Given this list of marker genes MACF1, ITGA4, CITED2, SKAP1, CD28, MUC1, SOCS6, CDH13, WASHC2C, HLA-DQA1, ACTG1, NF2, EBI3, IFNL1, PDPK1, RSU1, GNRH1, SNAI2, EMP2, BTNL2, CYTH1, CARMIL1, UBASH3B, ADAMDEC1, ILDR2, CARD11, CD37, KANK1 (NCBI Gene Id 23189), PLAU, HSPD1, CYLD, NR4A3, NDFIP1, NRP1, PIK3CD, MIR146A, SMARCC1, PRKG1, FSTL3, LRFN3, CTNNB1, MIR138-1, MIR125A, ERBB3 (NCBI Gene Id 619500), ARG2, F11R, FLOT2, MIR92A1, PLXNB1, SIRPB1, BMP6, NCKAP1L, FUT2, ADIPOQ, KLF4, PKHD1, SERPINE1, COL8A1, LMO7, TNN, MIR503, ZBTB7B, IL1RN (interleukin 1 receptor antagonist), TNC, FCHO1, CXCL8, RET, NFAT5, ROCK1, CORO2B, B2M, ADA, PNP, FUT7, PAG1, SEMA3E, ICOSLG, ACTL6B, RHOD, MIR10A, HES1 (NCBI Gene Id 3280), PRKAA1, CCDC80, DEFB118, SASH3, BTN2A2, GPM6B, LILRB1, PKP3, KAT5, TNFSF11, DSCAM, PIK3R2, CD55, CAV1, IL20RB, CSK, VTCN1, PODXL, TESPA1, EGFLAM, MIR222, LEP, TGFB1, PTPN23, LAX1, MIRLET7E, SMARCD3, DLC1, IRAK1, FAM107A, MINK1, EFNA5, SPINK5, DHPS, CXCR3, BMP7, SFRP2, ANXA1, ZAP70, EPHA8, SLC9A1, CCL21, CD86, CORO1C, HLA-E, PLG, CBLB, CLASP2, WDPCP, SERPINE2, SRC, PRSS2, PRKCD, AP3B1 (NCBI Gene Id 8546), RC3H1, DNAJA3, THBS1, PKP4, EFNB3, BTLA, PRKAR1A, DUSP22, HOXA7, GCNT1 (NCBI Gene Id 2650), HLA-DOB, HLA-DPB1, COL1A1, IL21, TNXB, PLPP3, PRKX, PIK3CG, VCL, CD300A, NPY2R, ETS1, PREX1, CD274, IL1A, SMARCD2, CFL1, JUP, IFNA2, ST3GAL4, CD6, TENM3, RASA1, APBB1IP, PIEZO1, CD63, FGG, SPRY4, FGL2, ITGA2, CRK, STX4, PTPN11, MAP4K4, RCC2, FOXJ1, MAPK7, HLA-DPA1, VWC2, DISC1, EPB41L5, TNFRSF21, TBCD, CLEC4G, MEGF10, LAMC1, PDCD1LG2, FUT9, CXCL13, XCL1, AKT1, ATM, PAWR, DOCK8, CD1D, FBXO38, HLA-DMB, HTN1, CEACAM6, IL4, CD44, PTPN1, AJAP1, SOCS5, MDGA1, ELANE (NCBI Gene Id 6417), KIF26B, SIRPA, TNR, RIPOR2, ADORA2A, MIR27A (microRNA 27a), RHOA, MAP2K1, RUNX3, PRKD2, WNK1, EPCAM, MUC21, ITGB1BP1, C1QBP, CASS4, LGALS3, SAA1, LIF, ARL2, WNT10B, PLA2G5, LIMS2, YES1, MIR21, KIF14, RHOH, LEF1 (lymphoid enhancer binding factor 1), MIR141, RASAL3, SWAP70, CLECL1P, SFRP1, C1QTNF1, DACT2 (NCBI Gene Id 353264, dishevelled binding antagonist of beta catenin 2), CDSN, MYADM, AKNA, OPA1, IHH, PLXND1, ASCL2, LAMB2, NUAK1, BCL2, RAG1, ZBTB16, RBPJ, PTPRU, ATXN3, METTL3, TMX1, IGFBP2, AP3D1, KLHL22, CHST2, RND1, MAD2L2, CX3CL1, PPP1CB (protein phosphatase 1 catalytic subunit beta), LILRB2, TNFSF18, PBRM1, PPARA, CCL28, HLA-DOA, UFL1, IDO1, EGR3, SOCS1, GPAM, UNC13D, TRPV4, TESK1, HMGB1 (NCBI Gene Id 3146), CALR, CRTAM, PLA2G2A, EPO, FBLN2, PLXNB2, PTPRA, ASS1, MIR221, BMP4, SCRIB, PLA2G2D, IL23R, IL6ST (NCBI Gene Id 3572), SEMA6A, CYP1B1, MIRLET7G, LILRB4, EFEMP2, HYAL1, EFNB1, CEBPB (CCAAT enhancer binding protein beta), PTPRO, ANGPT1, SPN, GPNMB, CDH1, RIN2, IL23A, ADAM10, HHLA2, TSPAN32, DSG2, PYCARD, TSC1, LIMS1, ADAM9, IFNG, DENND6A, ZC3H8, SHH, SLC4A2, FOXC2, ZP3, YWHAG, SELP, CD40LG, FOXO3, ITCH, NCK1, PPP1R12A, TGFB2, EPHA7, CCR7, CTSG, PPP3CA, GLI3, ACVRL1, RAC1, DPP4, HLA-DRB1, HLA-DQB2, FERMT3, DMP1, CASP3, DOCK5, ERBB2, XBP1, IL18, PLAUR, SMAD7, MAPK14, DMTN, SPI1, PTPRJ, CIB1, TNFSF14, LYN, GTPBP4, AP1AR, LPXN, LAMA1, ITGB3, SHB, ADAM8, IL4R, SRF, MAD1L1, FAF1, FADD, VAV3, PCK1, MALT1, EPHA3, IGF2, PTPN22, FXYD5, LCK, PRDX2, RAC2, TRAF6, PLET1, JAG2, CD9, MDK, PIK3R1, LDB1, PLXNB3, STK4, PRKCA, PEAK1, IL6, CHRD, VSIG4, COL16A1, PTPRR, LGALS1, LGALS9B, ABI3BP, JAK3, ANGPT2, TGFBI (transforming growth factor beta induced), ITGA5, ARHGDIG, UTRN, HAVCR2, PML, SPECC1L, ZDHHC21, PELI1, RRAS, FUT4, PIK3R6 (NCBI Gene Id 146850), AIF1, JAG1, CCN1 (NCBI Gene Id 3491), DUSP1, NEDD9, TNFSF13B (TNF superfamily member 13b), CD5, CYRIB (CYFIP related Rac1 interactor B), CBLL2, MIR128-1, MMP2, DDR1, LOXL3, IL12A, CASK, IL4I1, DAB1, SMARCE1, PKD1, VAV1, CCR2, VNN1, IL1B, MMP12, CD74, ADTRP, NR5A2, FZD7, TEK, MIR29C, EFNB2, CTLA4, TMIGD2, KLRK1, STAT5A, BAG4, FOXA1, SMARCA4, IL2RA, CD46, ITPKB, ILK, OLFM4, BCL6, WNT4, PLA2G2F, VIT, CXCL12, HRG, NOTCH1, DTX1, CSF1, CD69, TRIOBP, ABCA12, DUSP26 (NCBI Gene Id 79226), NDNF, S1PR1 (NCBI Gene Id 51546), SART1, DAG1, ARHGEF7, CYTH3, CD3E (CD3 epsilon subunit of T-cell receptor complex), HLA-DQB1, ONECUT1, MIR31, GPR4, PLXNC1, MYOC, FGA, WNT5A, HTR2A, TNFSF4, ZMIZ1 (zinc finger MIZ-type containing 1), RAG2, KDR, PDPN, NODAL, PPM1F, KLHL25, MELTF, HLA-A (major histocompatibility complex, class I, A), NOD2, TPM1, MBP, MIR9-1 (microRNA 9-1), ARPC2, IFT74, MARCHF7, ONECUT2, LGALS9, RDX, B4GALNT2, ZC3H12A, NRG1, RARA, BMP2, PDCD1, HACD1, HSPH1, AZU1, SERPINF2, TIGIT, CCL25, NRARP, ZNF703, ARID1B, RELA, ZFHX3, TMEM131L, DLG1, NEXMIF, PTPN6, CYTIP, NPY, AGER, SMAD3, SOX9, VSIR, C2CD4B, HLA-G, IL2RG, PIK3CB, TGM2, NF1, CSPG5, IGF1, WNT3A, FERMT2, ACTB, TFE3, FRMD5, RREB1, CCDC88B, FERMT1, LAMA3, CD81, TNFSF9, GP6, ADAM22, LGALS9C, FES (NCBI Gene Id 2242), SPTA1, PKP1, TFRC, SMARCA2, APOA1, LAG3, ARG1 (arginase 1), MYF5, PRLR, HLA-DMA, SEMA5A, PTEN, ACTL6A, FOXA2, BRAF, ITGA3, PRKCQ, ITGB2, RASGRP1, SMARCB1, SLAMF1, GBP1, SPOCK1, CELSR2, DLG5, HSD17B12, HLA-DQA2, SMARCC2, SOX2, FGB, TLN1, HLA-DRB5, GFUS, MIR939, GREM1, EMILIN1, NID1, AFDN, PKP2, ARID2, PTPN2, FUT1, GCNT2, SIPA1, TYK2, MIR519D, SMARCD1, TARM1 (T cell-interacting, activating receptor on myeloid cells 1), CEACAM1, SOX12 (SRY-box transcription factor 12), ADAM19, MAP2K5, PRNP, RGCC, CD209, RC3H2, NPNT, SLC7A1, TACSTD2, CD83, ALOX15, IL12B, ADAM15, IL12RB1, IL15, POLDIP2, CBLL1, EFNA1, TNFRSF18, EMILIN2, EPHB3 (NCBI Gene Id 2049), CCL19, IL2, DAB2, MIR675, HAS2, EPHA4, MAGI1, P2RY12, STX3, BAD, STAT5B, CRKL, CAMSAP3, LRRC32, ABL1, ADGRG1, MTOR, RAP1GAP, MIR181C, SELENOK, TBX21, SOX13, SOX4, FYN, IFNB1, SFN, MIR30B, CDKN2A, FUT3, ROCK2, PTK2B, CXCR4, FGL1, NLRP3, FOXP3, TNFRSF13C, LAMA5, IL10, MFSD2B, GSK3B, CDC42, LGALS8, BCL10, ACTN4, DAPK3, TNF (NCBI Gene Id 7124), ECM2, MYO10, JAK1, FLNA, DOCK1, SCGB1A1, CORO1A, P4HB, TMEM102, PTPRG, PTK2, NKAP, MIA3, TNFAIP8L2, TWSG1, FLOT1 (NCBI Gene Id 10211), ALOX12, RELL2, ENG, EPB41L4B, POSTN, MIR27B, NFKBIZ, TJP1, EP300, SPOCK2, CD70, FZD4 (NCBI Gene Id 8322), AGR2, ARID1A (NCBI Gene Id 8289), NCK2, PHLDB2, VCAM1, TGFBR2, BMI1, SLK, LAMA4, ABL2, SELE, S100A10, PCDH8, TESC, DAPL1, DLL1, VTN (NCBI Gene Id 7448), KITLG, ATP5F1B, JAK2, BRD4, LAMA2, ZDHHC2, BRD2, IRF1, CD24, KLRC4-KLRK1, ITGAV, VPS33B, PTPRC, ZBTB1, HLA-DRA, HLA-DRB3, WNT1, IL36B (NCBI Gene Id 27177), KIFAP3, EPHB2, IBSP, CCL2, SPINT2, ALOX5, ICOS, CLASP1, ARHGAP6, MIR192, BRD7, LIMCH1, CHST4, DUSP10, IL7R, EPHA2, APOD, CD160, PRKCE, RPS3, ZP4, CD276, SEMA4D, RAC3, HLA-DRB4, MMP14, ACER2, EDIL3, COL26A1, IL6R, CD36, TNFRSF14, KNG1, THY1, IL7, CR1, CD164, CBFB, CD4, LAPTM5, MIR183, SFTPD, PDGFB, MAP3K8, HSPG2, PDE3B, NOTCH4 (NCBI Gene Id 4855), JAM3, CDK6, GLMN, GATA3, C2CD4A, VEGFA, CCL5, AMBRA1, RUNX1, CD80, ADAMTS18, FN1, BST1, ANK3, HLX, HFE, RIPK2, SYK, FBLN1, SIRPG, PLEKHA2, CD47, SH2B3, RNASE10, CD27 (NCBI Gene Id 939), PHF10, MMRN1, EPHA1, GPR65, SDC4, GLI2, FOXF1, NFKBID, CELA2A, IL1RL2, YTHDF2, EGFL6, LAMB1, PRKCZ, DUSP3, here is a description of the gene set: Any process that modulates the frequency, rate or extent of attachment of a cell to another cell or to the extracellular matrix. species: Homo sapiens Human Gene Set: GOBP_REGULATION_OF_CELL_ADHESION